Given this list of marker genes TREX2, DUT, BCS1L, TXN, ETV4, SMC4, GINS1, CDKN3, RRM2, PDIA6, BCAR3, SMARCA4, NDC1, CDK2, LDLR, METTL3, FEN1, PMS1, IGF2BP2, CSNK2A1, TFB1M (transcription factor B1, mitochondrial), DNAJC9, STK39, HAT1 (histone acetyltransferase 1), CCNF (cyclin F), PALLD, MT1F, FN1, FASTKD1, POLRMT, AGFG1, ANP32E, IRAK1, HJURP, PLOD3, CNOT7, SAMD4A, RBM25, SUPT16H, PRPS1, TUBG1, NT5E, MAK16, CAP1, EXOSC8, ARF4, KDELR2, GCN1, CALM2, CKS2, VRK1, MT2A, SRSF10, MCM7, PRPF40A, MAP4K4, CDCP1, BARD1, PAICS, YWHAH, NSD2 (nuclear receptor binding SET domain protein 2), MCM3, ITGB5, EHD1, RANGRF, MUS81, NUDT15, UPP1, MT1X, CUTC, SHISAL1, HSP90B1, TTI1, ZWINT, TIMELESS, MCM6, ELK3, TTLL12, MCM4, EXPH5, RANBP1, PHC2 (polyhomeotic homolog 2), SF3B3, XPO6, USP1, GALE, C11orf24, RNF138, ANXA5, CLPB, CKS1B, CMC2, SRPK1, KIF4A, ME2, GNB1, DCAF15, NUP37, MELK, DVL1, MANF, SCD (stearoyl-CoA desaturase), MTHFD1, ACACA, NUP153 (nucleoporin 153), NUSAP1, SRRM1, FERMT1 (NCBI Gene Id 55612), PTTG1, UCHL5, ARHGDIA, TNFRSF12A, POLA1, NOP10, COL4A2, ASPM, KIF2C, UCK2, TXNDC5, XRCC3, LAMC2, FOSL1, RFWD3, FLNA, PRC1, PITRM1, FGFBP1, PRPF4, TEAD4, LYPLA1, HPCAL1, ILF3, DBF4 (DBF4-CDC7 kinase regulatory subunit), CENPX, CENPA, DNM1L, UBA1 (NCBI Gene Id 8247), IMPA1, HACD3, DDX11, PSMB2, GINS2, PRDX3, MBNL1, SH3TC1, IDI1, ACTG1, POP7, UBE2N, BIRC5, ANAPC5, MRPL35, WSB1, NUP107, POLE3 (NCBI Gene Id 54107), SNRPB, SMPD4, UBE2K, SRSF11, CALM1, SKP2 (S-phase kinase associated protein 2), WBP11, SSB, CDK1, DUSP4, DDX39B, SAE1, LARP4, ALG8, BLM, ACOT9, MT1H, EMC1, NOC2L, RNASEH2A, PHTF2, NAP1L1, SQLE, PRDX1, TIPIN, NUP205, DEPDC1, H2AZ2, FAM3C, SEC23B, COLGALT1, IMPDH1, CAMSAP2, CDC6, PLK1, ACTB, FOXM1, CYP51A1, PTGES3, TPRKB, ELOVL6, NASP, RFC3, AKT1, GFPT1, PARP2, TTC4, DHFR, EIF5B, CCT2, NOLC1, RAP1GDS1, DUSP6, GEMIN6, NUP188, PREB, CHAF1A, CKAP5, P3H4, MRPL17, CAD, PRKDC, FLNB, POLQ, FKBP4, SNRPA1, HMBS, PFN1, PPP2R2A, NCAPG2, RPA3, ACTN1, CDC45, AQR, TNFRSF6B, DHX15, NT5DC2, RAI14, PDLIM7, DTL, TTK, NUP85, SPRY2, TRIP13, ARL4C, CENPN, PAGR1, NDC80, AURKA, CSE1L, SRSF4, SNRPF, FANCI, VCL, SERPINE2, EEF1E1, MRPL3, CDC7, LDHA, PRMT5, HPS1, MCUR1, SMS, DNAJC10 (NCBI Gene Id 54431), PLAUR, EPHA2, TMPO, RCC1, GTF2H2, GCSH, PGK1, CDC25A, DROSHA, MCM2, H2AZ1, MSH6, RND3, UAP1, PLEK2, NIF3L1, SMTN, ODC1, RACGAP1, STK17A, MYH9, CDCA3, here is a description of the gene set: species: Homo sapiens Human Gene Set: FOURNIER_ACINAR_DEVELOPMENT_LATE_2 Genes identified by method 2 as coordinately down-regulated late in HMEC cells (mammary epithelium) during acinar development in vitro. from publication Fournier MV, Martin KJ, Kenny PA, Xhaja K, Bosch I, Yaswen P, Bissell MJ (PMID 16849555) Nonmalignant human mammary epithelial cells (HMEC) seeded in laminin-rich extracellular matrix (lrECM) form polarized acini and, in doing so, transit from a disorganized proliferating state to an organized growth-arrested state. We hypothesized that the gene expression pattern of organized and growth-arrested HMECs would share similarities with breast tumors with good prognoses. Using Affymetrix HG-U133A microarrays, we analyzed the expression of 22,283 gene transcripts in 184 (finite life span) and HMT3522 S1 (immortal nonmalignant) HMECs on successive days after seeding in a lrECM assay. Both HMECs underwent growth arrest in G0-G1 and differentiated into polarized acini between days 5 and 7. We identified gene expression changes with the same temporal pattern in both lines and examined the expression of these genes in a previously published panel of microarray data for 295 breast cancer samples. We show that genes that are significantly lower in the organized, growth-arrested HMEC than in their proliferating counterparts can be used to classify breast cancer patients into poor and good prognosis groups with high accuracy. This study represents a novel unsupervised approach to identifying breast cancer markers that may be of use clinically.